Given this list of marker genes Alkbh5, Tcf7, Gpr18, Mill1, Stat5b, Lef1, Ptprc, Cxadr, Gimap5, Scart2, Sox4, Rorc (RAR-related orphan receptor gamma), Lck, Jaml (NCBI Gene Id 270152), Sox13, Ccr9, Syk, Jag2, Itk, Stat5a, Skint1, Gimap3, Nckap1l, Egr3, here is a description of the gene set: studied in species Mus musculus Mouse Gene Set: GOBP_GAMMA_DELTA_T_CELL_ACTIVATION The change in morphology and behavior of a gamma-delta T cell resulting from exposure to a mitogen, cytokine, chemokine, cellular ligand, or an antigen for which it is specific.